Given this list of marker genes DOCK5, ZIC3, GRIA2, RGL1, RTKN2, XKR4, LSM4, USP37, CNTNAP2, SAMD4A, SLC25A12 (NCBI Gene Id 8604), DERL2, MRPL45, HES2, VEGFC, INSM2, GRIK2, ARMC8, RIDA, WDFY1, ORC1, MAP3K5, ADAMTS18, PAIP2B, ZNF184, DYNC1LI2, RRAGD, GRIP1, PTPRR, F2R, MFAP3L, IRF1, EID2 (EP300 interacting inhibitor of differentiation 2), ZNF704, NALCN, CNOT8, HECTD2, EGFL6, UPF2, RFX7, RNF19B, CBL, GFRA2, PPP3R2, TRPC6, CHMP7, BMP3, GFAP, CENPP, NIPSNAP3A, PHACTR4, TSPAN33, PCDH18, CCDC181, RNF146, GPBP1, KAT2B, CMC1 (NCBI Gene Id 152100), MRPS17, KL, TLR4, CEP43, YWHAH, RNF144A, QPCT, ZNF90, EXOSC5, NXPH1, POTEM, SLC44A1, ETV6, LSM3, TMEM65, CDC27, C2orf49, COL1A2, ESCO1, GAS6, SEC16B, DDI2, TFPI, TRPM6, SOS1, MAML1, CNNM4 (cyclin and CBS domain divalent metal cation transport mediator 4), FSBP, PIGA, ZNF367, CLASP2, ADAM28, RAD54B, SORCS3, RFX4, SLC7A11, USF2, ETV1 (ETS variant transcription factor 1), ZNF761, CREB5, SNX10, MAP3K2, TADA1, GLI3, ZC3H12B, SORT1, ZNRF3, GPM6A, CRTAP, SUCLG2, TMIGD1, LRIG3, NUSAP1, GABRG2, CAMTA1, KCND2, SLC2A2, NFAT5, ADAMTS6, SLC25A24, IYD, NR2E1, KCNAB2, ARPC1A, GNAI2, AFTPH, LMNTD1, HYCC1, ATP6V1G3, NSD2, MYEF2, BET1, CTSA, UBE3B, TMEM225, HGD, COMMD3-BMI1, ZBTB10, ADGRG2, IKZF2, TRMT5, LSM11, PIP4P2, IRAK1BP1, TBC1D23, PPP4R3B, NR4A3, SKIDA1, TBC1D15, WFDC13, GPR107, PARP12, CCN2, MYOZ1, ANO1, LSM8, CHAC2, NIPA1, PARP8, RFC1 (replication factor C subunit 1), NCK1, ADAM23, BCAT1, JAKMIP2 (janus kinase and microtubule interacting protein 2), CEP135, HERC2, ZNF782, SLC30A7, ZMYM2, KLHL31, GUSB, USP15, NOX4, KDM7A, PPP1R11, MS4A4A, MS4A6A, MLLT11, KRAS, ENTPD3, NRP2, SPAG9, CSNK1G3, TMED7-TICAM2, DTNA (dystrobrevin alpha), BORCS7, MAP3K8, BMI1, PIK3CB, DPP9 (dipeptidyl peptidase 9), PCDH19, FAM124A, SLC4A4, GTF2B, PKIA, KIN, ASIC1, ADCY1, MIER3, C5orf47, GAD1, CEP97, NAB1, RNF2, IPMK, TLR10, AGBL1 (AGBL carboxypeptidase 1), NRP1, CEP170, ADGRE3, KIAA1549, LSAMP, COL25A1, CFAP69, BMP2, RSRC1, RETREG1, PKP4, SORBS2, BDP1, METAP1, NUGGC, VAMP4, RABEP1, SHOX2, THAP12, TFDP2, CAPRIN1, KAT6B, GPSM2, FMN2, ACP1, PRKAA2, CCNYL1, GPCPD1 (glycerophosphocholine phosphodiesterase 1), LPP, PCMTD1, PPT2, TIMM23B, DSE, TRIM36, PPTC7, PABPC1, NUP58, ZNF701, NUDT13, TRA2B, SLC5A3 (NCBI Gene Id 6526), DLEU7, COL21A1, KIF21A, TMEM170A, SLC35F1, IRF6, AQP11, AASS, WWP2, MS4A6E, TIMM9, COG2, BICRAL, PLEKHA7, ANKRD44, SRRM4, PLEKHF2, CADM2, ZBTB20, ANTXR2, ADGRG6, CEP41, ZSCAN20, ZFP42, ZNF781, ERBIN, LYST, PRMT3, ZNF354C (NCBI Gene Id 30832), HADHB, TRPS1, MYO5A, ST8SIA4, IPO7, ZFHX4, RPS6KA5 (ribosomal protein S6 kinase A5), DCUN1D1, CACNB4, ESYT3, IBTK, SLIT3, DDX3X, GALNT13, SLC36A3, GAPVD1, ZNF124, RMND5A, AMTN, ACBD3, ATP10D, ZNF568, LEPROTL1, SIM1, COL11A1, MSRB3, EVI5, MICAL3, TMEM68, RIPOR2, KPNA4, SPRED1, ODC1, ARHGAP35, SMG7, RLIM, NKX2-2, REEP5, EDEM3, TSPYL1, ILF3, PFDN4, NAPG (NCBI Gene Id 8774), ARHGEF11, ACER3, ATP8B1, MS4A7, ZNF92, PEX3, ZNF81, UTP18, NUDT5, SLC6A15, LRBA, KLF7, CCN1, GLCCI1, CCDC148, PDE1C, INHBC, LAMA3, MGAT4A, NCAPG, MAPK1IP1L, PDS5B, GRM3, SLC1A3 (solute carrier family 1 member 3), UBE2I (NCBI Gene Id 7329), MCM4, SLITRK1, RNF169, ZNF3, JRK, UBE2D2, B4GALT6, KCNAB1, SMAD6, GNG11, ZNF436, RBFOX1, THRB, BCL2A1, ATXN7, FBXO33, UBR1, OGG1, PPM1B, YWHAQ, SPTLC3, here is a description of the gene set: Human Gene Set: MIR587 Genes predicted to be targets of miRBase v22 microRNA hsa-miR-587 in miRDB v6.0 with MirTarget v4 prediction scores > 80 (high confidence targets). studied in species Homo sapiens from publication Chen Y, Wang X (PMID 31504780)